The following is a description of a gene set: studied in species Mus musculus Genes negatively differentially expressed in cell type: MigDC (migratory dendritic cell) upon treatment with cytokine: IL-36α in mouse lymph nodes in vivo. from publication Cui A, Huang T, Li S, Ma A, Pérez JL, Sander C, Keskin DB, Wu CJ, Fraenkel E, Hacohen N (PMID 38057668) Cytokines mediate cell-cell communication in the immune system and represent important therapeutic targets. A myriad of studies have highlighted their central role in immune function, yet we lack a global view of the cellular responses of each immune cell type to each cytokine. To address this gap, the authors created the Immune Dictionary, a compendium of single-cell transcriptomic profiles of more than 17 immune cell types in response to each of 86 cytokines (>1,400 cytokine-cell type combinations) in mouse lymph nodes in vivo. A cytokine-centric view of the dictionary revealed that most cytokines induce highly cell-type-specific responses. For example, the inflammatory cytokine interleukin-1β induces distinct gene programmes in almost every cell type. A cell-type-centric view of the dictionary identified more than 66 cytokine-driven cellular polarization states across immune cell types, including previously uncharacterized states such as an interleukin-18-induced polyfunctional natural killer cell state. Mouse Gene Set: CUI_MIGDC_IL36A_RESPONSE_DN, and this is the list of marker genes: Fam53b, Creg1, H2-Q6, Ctsh, Klf2, Eno3, H2-M2, Chka (choline kinase alpha), Zfp36l1, Sat1, Tspan3, Slc6a6, Wdr91, Zmynd15, Laptm5, Ftl1, Crip1 (cysteine-rich protein 1), Rptor, Fuca1, Icosl, Ucp2, Rgs3, Tnfrsf1b, Nav1, Anxa3, Tmem176b, Fosb, H3f3b, Ubc, Brk1, Cxcl16